Given this list of marker genes SOST, PHEX, DHCR24, CLCN7, PTH1R, CTSK, LRP5, TCIRG1, PLEKHM1 (NCBI Gene Id 9842), here is a description of the gene set: An abnormal increase of bone mineral density with generalized involvement of the skeleton. Human Gene Set: HP_GENERALIZED_OSTEOSCLEROSIS studied in species Homo sapiens Generalized osteosclerosis